Given this list of marker genes Zc3h4, Hic2, Pdcd1lg2, Trappc9, Cp, Adi1, Kl, Col24a1, Nyap2, Bltp3a, St6gal2, Nhsl2, Hif1an, Tango6, Hoxa1, Nrbf2, Adarb2, Pakap, Dhfr, Spsb4, Nudt9, Tbxas1, Ccdc22, Rap2a, Zfp128, Map3k9, Septin3, Kcns3, Fgf5, Dennd11 (NCBI Gene Id 243780), Tmod2, Tmem161b, Ppp1r3d, Chdh, Eva1a, Cstf2, Samd4b (sterile alpha motif domain containing 4B), Zfp710, Wdr26, Ifih1, Arrdc3, Slc7a1, Tbc1d22b, Heatr6, Wdr1, Grsf1, Tomm20, Szrd1, Notch1, Prrg3, Syn3, Epha5, Gas2l3, Recql5, Tmem170b, Dock11, Itsn1, BC107364, Elavl3, Plcd3, Brinp2, here is a description of the gene set: Mouse Gene Set: MIR_7018_3P Genes predicted to be targets of miRBase v22 microRNA mmu_miR_7018_3p in miRDB v6.0 with MirTarget v4 prediction scores > 80 (high confidence targets). from publication Chen Y, Wang X (PMID 31504780) studied in species Mus musculus